The following is a description of a gene set: studied in species Mus musculus A developmental process, independent of morphogenetic (shape) change, that is required for the hindbrain to attain its fully functional state. The hindbrain is the region consisting of the medulla, pons and cerebellum. Areas of the hindbrain control motor and autonomic functions. Mouse Gene Set: GOBP_HINDBRAIN_MATURATION, and this is the list of marker genes: Rere, Grin1, Cacna1a, Cdk5r2, Cend1, Cdk5r1, Arcn1